The following is a description of a gene set: from publication Haddad R, Guardiola P, Izac B, Thibault C, Radich J, Delezoide AL, Baillou C, Lemoine FM, Gluckman JC, Pflumio F, Canque B (PMID 15331438) studied in species Homo sapiens Genes up-regulated in hematopoietic progenitor cells (HPC) of T lymphocyte and NK (natural killer) lineage. Human Gene Set: HADDAD_T_LYMPHOCYTE_AND_NK_PROGENITOR_UP The early stages of human lymphopoiesis are poorly characterized. Here, we compared the lymphoid potential of a novel umbilical cord blood CD34(+)CD45RA(hi)CD7(+) hematopoietic progenitor cell (HPC) population with that of CD34(+)CD45RA(hi)Lin(-)CD10(+) HPCs, previously proposed as candidate common lymphoid progenitors. Limiting-dilution and clonal analysis, fetal thymic organ cultures, and culture onto Notch ligand Delta-like-1-expressing OP9 cells, showed that although CD34(+)CD45RA(hi)CD7(+) HPCs could generate cells of the 3 lymphoid lineages, their potential was skewed toward the T/natural killer (T/NK) lineages. In contrast, CD34(+)CD45RA(hi)Lin(-)CD10(+) HPCs predominantly exhibited a B-cell potential. Gene expression profiling with DNA microarrays confirmed that CD34(+)CD45RA(hi)CD7(+) HPCs selectively expressed T-lymphoid and NK lineage-committed genes while retaining expression of genes affiliated to the granulomonocytic lineage, whereas CD34(+)CD45RA(hi)Lin(-)CD10(+) HPCs displayed a typical pro-B-cell transcription profile and essentially lacked genes unrelated to the B lineage. In addition, both populations could be generated in vitro from CD34(+)CD45RA(int)CD7(-) and CD34(+)CD45RA(hi)Lin(-) HPCs with mixed lymphomyeloid potential, from which they emerged independently with different growth/differentiation factor requirements. These findings indicate that CD34(+)CD45RA(hi)CD7(+) and CD34(+)CD45RA(hi)Lin(-)CD10(+) HPCs correspond to multipotent early lymphoid progenitors polarized toward either the T/NK or B lineage, respectively., and this is the list of marker genes: TPM1, FAM3C, DLK1, MYH10, BCLAF1, COL5A1, BEX1, CDC14B, SMAD7 (SMAD family member 7), FAM124B, RASA1, PLCB4, ID3, PHF3, TNFSF10, CACNB2, CRHBP (NCBI Gene Id 1393), PPM1H, HSPB1, TRO, HSPA5, WASHC4, F2RL1, BAG3, GRK5, ARMCX1, TAL1, HMGA2, RIOK3, FOXO1, MEG3, TJP2, PTPRD, HLA-DQA1, HLF, DDX17, CCDC88A, FAM117A (family with sequence similarity 117 member A), ARMCX2, DACH1, PDZD2, ZNF148 (NCBI Gene Id 7707), LOX, CFH (NCBI Gene Id 3076), INPP4B, ASAP2, MSH2, HSPA13, HLA-DRB4, ADGRG6, FXR1, PBX1, ZNF165, CAVIN1, ALDH1A1, PLXDC2, KLF9, LAPTM4B, PTK2, MPDZ, NPR3, PSEN2, MECOM, PLOD2, ILF3, LRIG1, TIMP3, CHN2, GP1BB, DNAJC6 (DnaJ heat shock protein family (Hsp40) member C6), MDK, ANK3, SERPINI1, MLLT3, PRG2, FOXO3, SMARCA2, PHLPP1, GATA3, HTR1F, ARG2